The following is a description of a gene set: from publication Anandasabapathy N, Victora GD, Meredith M, Feder R, Dong B, Kluger C, Yao K, Dustin ML, Nussenzweig MC, Steinman RM, Liu K (PMID 21788405) species: Homo sapiens Human Gene Set: GSE29949_CD8_POS_DC_SPLEEN_VS_MONOCYTE_BONE_MARROW_DN To understand the functional relationship between brain dendritic cells (brain DCs) and other myeloid cells, we compared the gene expression profile of m/chDCs to that of bone marrow monocytes, brain microglia and classical spleen CD8+ and CD8- DCs. In order to obtain enough brain DCs for mRNA extraction, we expanded brain DCs with in vivo Flt3L treatment before purification. Genes down-regulated in spleen CD8+ dendritic cells versus bone marrow monocytes., and this is the list of marker genes: ITPR1, ACADS, TMEM123, FST, EIF2S2, PLK4, RPS17, PPM1B, TUBGCP3, CASP9, BICD2, MPO, RYBP, CST7, NONO, CPNE1, PMM1, RNF187, ADAM5, MRTFA, CDH2, MNAT1, IER3, HAX1, SSTR5, RMND5A, GRM1, ETV4, PPP2R3A, GRAMD1B, FTL, PYROXD1, ASS1, BTBD3, SP140, COX4I1, GALNT3, CDH3, ZBTB48, CBARP, MAP1LC3B, BCAT1, RRM2, IL12RB2, MTIF2, GABRA6, KLF6, C11orf58, OXA1L, EIF4EBP1, EIF1, NR2F6, APOOL, IRAG2, ZNF184, IMPA1, IQCE, BCL3, RBBP8, RDH16, ATG12, ERP29, SIK3, FLOT1, FGFR1, EGR4, PMF1, ZNF85, RCN1, EIF4H, CARS1, IL1R1, PSG11, LRP4, SERPINB8, BMP3, TM4SF1, TMOD1, RPL19, CBLB, ARL6IP5, PRKX, RNF113A, DHPS, PMPCB, NAMPT, LAG3, COPB1, ST6GAL1, IFI35, PRSS12, BNC1, CD48, ARL1, CENPI, MTHFS, ATP1A2, KCTD2, ZNF7, SH2D1A (SH2 domain containing 1A), GFER, SATB1, MAPKBP1, CREM, TMEM63A, ISG20, KLHL9, CHRNA2, MUTYH, VAMP7, NACA, HDAC4, GIP, MIA2, ANP32E, CEBPG, SI, EFNB3, IBTK, CXCL2, PNOC, SYNE1, ZBTB7B, BAG6, FLI1, IL18R1, OSTF1, RPS27, STK10, ECM1, OPHN1, NCAM1, SHMT2, AP3S1, FXN (NCBI Gene Id 2395), PIK3C2G, ST8SIA4, GRK3, ELP4, ECI1, GBP2, SASH3, SERINC5, PHC2, PRNP, DCAF11, ABCD3 (NCBI Gene Id 5825), ASNS, PEX10, NEK9, STAM2, RIOK3, ELK1, RPL27A (NCBI Gene Id 84736), SCML2, ACR, LRRN3, STAG2, OVGP1, BYSL, DTX4, ARHGAP25, ELF4, CITED2, PRKAA1, RPS23, ALDOC, CCT8, GPR65, PLCD1, NEFL, CEBPB, MTUS1, SOX1 (NCBI Gene Id 6656), SP100 (NCBI Gene Id 6672), SLC30A4, TP53BP2, MDC1, STX4, UBE2H, DTNB, SERTAD2, FKBP5, HMX1, PPP1R12A, LASP1, CCN1, KCNJ1, CD28, MYRF, PRKY, NFKBIL1, FYN, TNFSF8, MKRN1, ANXA11, PRKAR1B, ATP8B1, OSR2